Given this list of marker genes CLOCK, PBX1, INPP4B, SOX13, TCEAL1, SOX4, DAAM1, FGF13, POU2F3, PLCB4, GATA2, HSPB1, FOXN3, MYLK, MAP3K1, BCL6, INHBB, ARID4A, FZD7, ITPKB, STAT2 (NCBI Gene Id 6773), IL15RA, CDC45, NR3C2, RBL1, CXCR4, PAK3 (p21 (RAC1) activated kinase 3), KDM5B, SATB1 (NCBI Gene Id 6304), TNFSF10, PDGFB, STIP1, ARNT, ZKSCAN1, ZBTB18 (NCBI Gene Id 10472), CDC6, IL13RA1, CITED2, IL6, FGFR2, ELF3, GATA3, CDC25A, NR2F2, here is a description of the gene set: species: Homo sapiens Amplification of the 8p11-12 region occurs in 15-20% of breast cancers, but the driving oncogene at this locus has yet to be definitively identified. We mapped the 8p11-12 amplicon in breast cancer cell lines and primary human breast cancers and identified the candidate oncogene human Sm-like protein (hLsm1, LSM1) based on increases in copy number and expression level relative to human mammary epithelial cells. To examine the oncogenic role of LSM1, we overexpressed this gene in MCF10A mammary epithelial cells and inhibited its production in the SUM44 breast cancer cell line, which has a natural amplification and overexpression of LSM1. Our data confirmed that LSM1 is an oncogene from the 8p11-12 amplicon by showing that hLsm1 overexpression induced growth factor-independent proliferation and soft agar colony formation in MCF10A cells, and hLsm1 inhibition in SUM44 cells dramatically reduced soft agar growth. Little is known about hLsm1 function other than its involvement in mRNA degradation; therefore, we used expression microarray analysis to investigate how hLsm1 affects cell transformation in MCF10A and SUM44 cells. We identified numerous genes altered following hLsm1 overexpression common to SUM44 breast cancer cells that play important roles in cell cycle regulation, cell proliferation and other cancer-promoting processes. Future work will continue to characterize these important changes to achieve a more complete understanding of the mechanism of hLsm1's effect on cancer progression. Genes up-regulated in MCF10A cells (breast cancer) by expression of LSM1 off a letiviral vector. from publication Streicher KL, Yang ZQ, Draghici S, Ethier SP (PMID 17001308) Human Gene Set: STREICHER_LSM1_TARGETS_UP